Given this list of marker genes Nupr2, Htra2, Zdhhc16, Fbxo6 (F-box protein 6), Ascc1, Parg, Dynll1, Vcp, Brca2, Hmgb1 (high mobility group box 1), Fbxo45, Nipbl, Spo11, Cgas, Actr5, Alkbh1, Brcc3, Ino80d, Ints3, Pidd1, Taf5 (NCBI Gene Id 226182), Firrm, Rad23b, Ccnk, Faap20, Topors, Hmga1, Exosc10, Rad51 (NCBI Gene Id 99282), Ascc2, Alkbh7, Psmd14 (NCBI Gene Id 98839), Traf6 (TNF receptor-associated factor 6), Brd4, Cdk2, Morc2a, Msh6, Tank, Pds5a, Fmr1, Ep300, Trp63, Taok2, Atrx, Mrgbp, Ggn, Taf7, Stk38, Endov, Ppp4r3c2, Morf4l1, Cdc5lrt4, Gfi1, Polb, Baz1b, Ankle1, Dyrk1a, Snai1, Mcm6, Nek11, Prmt1, Aunip, Bcl2a1a, Ercc8, Actb, Pak1, Sgk1 (serum/glucocorticoid regulated kinase 1), Atxn7l3, Myo6, Btg2, Taf5l, Usp45, Cib1, Msh3, Apex2, Phlda3, Pole3, Ung, Rnf111, Taok3, Rad1, Cdc5lrt1, Tex264, Cdkn1a, Hsf1, Twist1, Mapk1, Majin, Fh1, Cdc14b, Senp3, Wrn, Eepd1, Ints7, Tfap4, Tnfrsf1b, Slf2, Plk1, Dtl, Ifi211 (NCBI Gene Id 381308), Rev3l, Ubr5, Ddx5, Xiap, Fnip2, Prmt6, Faap24, Bcl2l1, Fanci, Bcl7a, Stk33, Cdkn2d, Cdk1, Exo5, Snai2, Bad, Smarca2, Rbm24, Hmga2, Mtch2, Actr2, Hdac10, Mutyh, Cdc5lrt5, Ap5z1, Supt20, Grb2, Xrcc6 (X-ray repair complementing defective repair in Chinese hamster cells 6), Rbx1-ps, Msl2, Pnkp, Ppp4r3a, Yju2, Atxn7, Smc3, Mrnip (NCBI Gene Id 72859), Pif1, Smarca4, Polk, Xrcc5, Poldip2, Shprh, Wac, Fam168a, Usp22, Armt1, Cdc5lrt9, Ccnd1, Fzr1 (fizzy and cell division cycle 20 related 1), Sfpq, Usp1, Pmaip1, Dot1l, Dyrk1b, Fmn2, Mbtd1, Mtrex, Ercc6l2, Fignl1, Crebbp, Kat7, Xrcc3, Ap5s1, Pole, Batf, Zbtb40 (NCBI Gene Id 230848), Eef1e1, D7Ertd443e, Ube2a, Terf2ip, Parp10, Cd44, Moap1, Ufl1, Rbbp5, Kmt5b, Atr, Pcna, Tipin, Taf6l, Ier3, Rnf126, Clock, Gtf2h3, Dyrk2, Mdm4, Spata18, Ube2e2, Ube2n, Alkbh3, Kif22, Nfatc2, Prdm9, Morc2b, Cdc5lrt6, Pttg1ip, Gins4, Lig4, Smchd1, Susd6, Primpol, Helb, Bbc3, Cdk5rap3, Exd2, Trip12, Eif2ak4, Ruvbl2, Terb1, Bcl6, Poln, Inip, Cfap410, Bcl2l12, Smarce1, Paxip1, Otud4, Smarcc1, Fanca, Ube2d3, Ticrr, Mbtps1, Pagr1a, Nuggc, Ppp1ca, Abl1, Ercc2, Vps72, Smarcad1, Shld3, Egfr, Cul4a, Tdg-ps, Traip, Cbx1, Cep63, Cetn2, Recql4 (RecQ protein-like 4), Hic1, Ncoa6, Pnp, H2ax, Fancl, Stxbp4, Dna2, Axin2, Vrk2, Nuak1, Ercc4, Nscme3l, Tonsl, Tpt1, Dele1, Shld1, Ino80, Hpf1, Uaca (uveal autoantigen with coiled-coil domains and ankyrin repeats), Setd2, Pold1, Mbtps2, Ercc3, Rad51ap1, Bax, Ifi204, Rptor, Clu, Bod1l, Mtor, Marf1, Zbtb1, Taf9, Aste1, Mcts1 (NCBI Gene Id 68995), Uba1y, Setmar, Uvssa, Nsmce3, Uba6, Foxp1, Chchd6, Foxn3, Neurl4, Rmi1, Parp1, Rfwd3, Setd7, Smarcd3, Map3k20, Ppp2r5c, Ddb2, Hmces, Radx, Plscr1, Rnf138, Aptx, Mc1r, Casp2, Usp9x, Cdc7, Mdc1, Htatsf1, Rad23a, Bard1, Rbbp4, Gtf2h1, Rpl26, Sycp3, Ddias, Timeless, Smc1a, Slx4, Crip1, Pogz, Chek1, Brcc3dc, Endog, Rad51b (NCBI Gene Id 19363), Hinfp, Zfp830, Zgrf1, Rnaseh2b, Kmt5a, Setx, Swsap1, Mcm3, Tdp1, Syf2, Pole2, Ptpn11, Mcm2, Klhl15, Brd8, Pms1, Ino80b, Zfp365, Rtel1, Ddx11, Cry1, Fancf, Cdc45, Kat5, Nfrkb, Rev1 (NCBI Gene Id 98573), Ing4, Sirt1, Rad52, Cdk5, Hrob, Bcl3, Psen1, Slx1b, Trim39, Nek4, Fan1, Taf10, Shld2, Brme1, Lyn, Rif1, Hdgfl2, Poll, Tigar, Recql, Steap3, Ppp1r10 (protein phosphatase 1, regulatory subunit 10), Trp53bp1 (transformation related protein 53 binding protein 1), Rpa2, Yap1, Nabp1, Pot1b (protection of telomeres 1B), Polq, Wrap53, Vrk3, Sem1, Smarcc2, Babam2, Nthl1, Prkdc, Kat2a, Ackr3, Chd1l, Ptprv, Mcm4, Mnat1, Actl6a (actin-like 6A), Meaf6, Mapk15, Mcm5, Top2b (NCBI Gene Id 319393), Spire1, Hus1 (NCBI Gene Id 15574), Kdm2a (lysine (K)-specific demethylase 2A), Xpa, Usp16, Ell3, Helq, Trex1 (NCBI Gene Id 22040), Bclaf1, Hmox1, Tmem161a, Chaf1a, Nme3, Sfr1, Donson, Nsd2, Gnl1, Polg, Smyd2, Uba1, Usp28, Bach1, Stk19, Oard1, Fancb, Neil2, Riox1, E230001N04Rik, Sf3b5, Marchf7, Phf10 (NCBI Gene Id 72057), Peli1, Mael, Sgf29, Chek2, Foxo3, Taf2, Mapt, Psmd10, Tnp1, Rrm2b, Prpf19, Cdc5lrt8, Pttg1, Spire2, Prap1, Immp2l, Tmem109, Xrn2, Sesn2, Top3b, Fen1, Rfc1, Dclre1b, Eya2, Knl1, Brip1 (BRCA1 interacting protein C-terminal helicase 1), Pclaf, Smarcal1, Morf4l2, Hltf, Brat1, Uri1, Hdac9, Mcm8, Plk5, Ctc1, Cdca5, Rexo4, Dcun1d5 (defective in cullin neddylation 1 domain containing 5), Fus, Foxo4, Epha2, Dhx9, Spindoc, Babam1, 4930447C04Rik, E2f7, Pla2r1, Otub1, Ddx1, Suv39h1, Hmga1b, Cinp, Spdya, Parp2, Cdk6, Ooep, Uvrag (NCBI Gene Id 78610), Ctla4, Uimc1, Msh2, Triap1, Mcm10, Rbbp8, Yeats4, Mus81, Adprs, Trrap, Bcl7b, Exo1, Mdm2, Rad51d, Casp3, Uchl5, Rpain, Mta1, Wdr48, Npm1, Rint1, Sox4, Dclre1c, Cdc5lrt7, Zmynd8, Usp3, Wdr4, Esco2, Mapk14, Mcrs1, Rmi2, Bcl7c, Cip2a, Pold4, Xrcc1, Meioc, Dntt, Zswim7, Spred2, Tdp2, Terb2, Mre11a, Sycp1, Fbxw7, Samhd1, Rnaseh2c, Mill1, Chd2, Rnf138rt1, Chaf1b, Zcwpw1, Ndufs6, Eya3, Trex2, Skp2, Skil, Zfyve26, Trp53, Kmt5c, Prkcd, Tfpt, Kash5, Nudt16l1, Pycard, Neil3, Foxm1, Mif, Bcl2l11, Cdip1, Alkbh8, Cbx3, Phf1, Parp9, Bcl2l2, Csnk2a2, Pold2, Usp47, Emsy, Fam111a, Usp10, Spata22, Cdc5l, Nfat5, Macrod2, Atf2, Ppm1d, Zmpste24, Fancc, Mlh1, Fto, Hnrnpk, Bid, Was, Polg2, Zfp385a, Smc6, Ndrg1, Epc1, Bcl2a1b (NCBI Gene Id 12045), Mettl3 (NCBI Gene Id 80554), Fbxo5, Tex15, Mapkapk2, Wdr76, Polr2i, Mlst8, Muc1, Pierce1, Ifi205, Rad54l, Ep400, Tnks1bp1, Eme1, Ccng1, Bok, Brca1, Trim28, Zc3h12a, Atrip, Nsmce2, Cdc5lrt10, Supt7l, Gen1, Nfatc4, Nsmce4a, Eny2, Nkx3-1, Xrcc4, Dgkz, Smarcd2, Xpc, Dmap1, Topbp1, Fancd2, Msh5, Swi5, Actl6b, Parp3, Arid2, Meiob, Znhit1, Pms2, Cdk9, Vav3, Xrcc2, Mcmdc2 (minichromosome maintenance domain containing 2, NCBI Gene Id 240697), Plk3, Tti1, Ppp4c, Snw1, Fbxo31, Ssrp1, Terf2, Eme2, Nsmce1, Pds5b, Mad2l2, Phf13, Sirt4, Blm, Zfp668, Mcl1, Smc4, Nop53, Ercc5, Bcl2, Cebpg, Ankrd1, Rnf8, E2f1, Apc, Tiprl, Cul4b, Eya4, Aim2, Gins2, Pwwp3a, Myc, Zranb3, Rnaseh2a, Atmin, Atad5 (NCBI Gene Id 319895), Rad50, Mms22l, Rad21l, Alkbh2, Bend2, Bcl2l10, Psme4, Fancm, Ttf2, Usp51, Huwe1 (NCBI Gene Id 97602), Tex12, Rrm1, Fem1b, Tada3, Dmc1, Gigyf2, Ppp4r2, Men1, Trp73, Brd7, Cbl, Apex1, Akt1, Atad3a, Ppp4r3c1, Kat2b, Commd1, Bcl2a1d, Gnb1l, Rad51c, Arid1a, Pot1a, Ubqln4, Stk11, Setd1a, Nrde2, Nhej1, Hsf2bp, Smc2, Iffo1, Yy1, Ercc6, Cd74, Tnf, Ercc1 (NCBI Gene Id 13870), Rad18, Rbbp6, Egln3, Chd4, Sprtn, Nacc2, Wnt1, Recql5, Foxo1, Top2a, Hipk1, Hus1b, Pml, Sirt6, Bak1, Ube2b, Ccdc117, C1qbp, Actr8, Acd, Ppp4r3b, Supt16, Spidr, Sod2, Taf12, Epc2, Cbx5, Mgmt, Gtf2h2, Chrna4, Usp7 (ubiquitin specific peptidase 7), Zmat3, Ddb1, Cops3, H2ac25, Ttc5, Ei24, Dek, Npas2, Rps3, Kdm1a, Rbm38, Etaa1, Rad54b, Pias1, Park7, Hipk2, Clspn, Ing3, Abraxas1, Asf1a, Hspa1a, Ikbkg, Mbd4, Uhrf1, Shisa5 (NCBI Gene Id 67794), Zbtb38, Rnf169, Eya1, Mapk3, Nek1, Msh4, Dpf1, Dpf2, Rps6ka6, Pold3, Bmyc, Nucks1, Rpa1, Cenpx, Dtx3l (NCBI Gene Id 209200), Smarcb1, Dpf3, Aplf, Fancg, Ruvbl1, Flywch1, Rassf1, Brsk1, Polh, Tada1, Wdhd1, Kdm4d, Nupr1 (nuclear protein transcription regulator 1), Rps27l, Zbtb7a, Ino80c, Vcpip1, Nedd4, Rfc5, Neil1, Ddit4, Nbn, Rhno1, Hmgn1, Stub1, Rad9b, Mpg, Vrk1 (NCBI Gene Id 22367), Zbtb4, Acer2, Jmy, Trip13, Mcm7 (NCBI Gene Id 17220), Nabp2, Bccip, Paxx, Mlh3, Lig1, Smarcd1, Mastl, Smc5, Smug1, Cdkn3, Top3a, Wrnip1, Ugt1a1, Fbh1 (NCBI Gene Id 99172), Ccdc13 (NCBI Gene Id 72894), Sfn, Smg1, Macrod1, Ogg1, Rnf168, Nono, Uba7, Mms19, Rfc4, Casp9, Pias4 (protein inhibitor of activated STAT 4), Parpbp, Ikbke, Gtf2h5, Eid3, Ascc3, Rbx1, Trpc2, Dgcr8, Palb2, Spred1, Rad17, Ager, Creb3l1, Pik3r1, Rfc3, Aktip, Rfc2, Atm, Mgme1, Khdc3, Bag6, Sde2, Herc2, Chchd4, Ercc6l, Fgf10, Pbrm1, Cdk7, Sf3b3, Smarca5, Apbb1, Pola1, Kin, Cdkn2a, Ube2v1 (ubiquitin-conjugating enzyme E2 variant 1), Cep164, Hdac3, Upf1, Mcm9, Xab2, Taf6, Slf1, Aen, Sp100, Tlk1, Ube2t, Cyren, Macroh2a1, Ube2w, Faap100, Lig3, Poli, Rad21, Ube2v2, Sirt7, Csnk2a1, Fbxo4, Tlk2, Gadd45a, Rpa3, Tdg, Polm, Cenps, Dyrk3, Rec8 (NCBI Gene Id 56739), Gtf2h4, Trim32, Pcbp4, Dclre1a, Tnfrsf1a, Cxcl12, Taok1, Cdkn2aip, Cbx8, Cradd, Rad9a, Prkcg, Mpnd, Ccar2, Bcl2a1c, Ash2l, here is a description of the gene set: Any process that results in a change in state or activity of a cell (in terms of movement, secretion, enzyme production, gene expression, etc.) as a result of a stimulus indicating damage to its DNA from environmental insults or errors during metabolism. studied in species Mus musculus Mouse Gene Set: GOBP_DNA_DAMAGE_RESPONSE